The following is a description of a gene set: species: Homo sapiens An elevated level of the enzyme lactate dehydrogenase in the blood circulation. Increased circulating lactate dehydrogenase concentration Human Gene Set: HP_INCREASED_CIRCULATING_LACTATE_DEHYDROGENASE_CONCENTRATION, and this is the list of marker genes: TOMM7, TP53, ACAD9, TCIRG1 (T cell immune regulator 1, ATPase H+ transporting V0 subunit a3), CPT2, LARGE1, PIEZO1, CFI, HLA-DRB1, MYCN, PLEC, XK, SPP1 (NCBI Gene Id 6696), PIGA, SLC4A1, MYC, CALR, MVK, PHOX2B, HACE1, AKR1D1, LIPA, JAK2, OBSCN, HBB, STAT4, TET2, DHFR, CAV3, PFKM, CFH, PSMB9, SLC25A13, AIFM1, KCNN4, SLC7A7, ALDOA, GAA, KY, MTHFD1, RHCE, PNPLA2, HMOX1 (heme oxygenase 1), USB1, ALK, HELLPAR, RHD, LMO1, BCL6, FLI1, PLA2G6, PIK3CG, RHAG, MLIP, PEX2, RB1, CHEK2, MT-CO3, VPS13A, LIN28B, MPL, STIM1, CBLIF, ABCG8, CD46, CDAN1, KIF23, SAT1, RPS14, PITRM1, MT-CO1, LPIN1, BCL2, NSUN2, IRAK1, OCRL, HMGCS2, ZNFX1, LYST, SLC19A1, KLF1, GCLC